Given this list of marker genes CA6, PTPRG, CA2, HADHA (hydroxyacyl-CoA dehydrogenase trifunctional multienzyme complex subunit alpha), AUH, ACO2, CA11, FH, ECHS1, EHHADH, UROS, CBS, HADHB, ACO1, ECH1, CA4, CA5A, ENO2, PCBD1, CA8, PTS, here is a description of the gene set: Genes in the cancer module 295. Human Gene Set: MODULE_295 species: Homo sapiens